The following is a description of a gene set: A conjunction of signaling from the T cell receptor, Interferon gamma (IFNG), and Interleukin-12 (IL12) induces the differentiation of T helper 1 cells (Th1) by activating the master regulator TBX21 (T-bet). Expression of TBX21 (T-bet) occurs in two phases. The first phase is dependent on IFNG acting via STAT1 and the T cell receptor acting via calcium, calcineurin, and NFATC1 (inferred from mouse homologs in Zhong et al. 2025). During the first phase, TBX21 activates expression of IL21RB2, a subunit of the receptor for IL12 (inferred from mouse homologs in Mullen et al. 2001, Afkarian et al. 2002, Schulz et al. 2009, Zhu et al. 2012). The second phase is dependent on IL12 acting via IL21RB2 and STAT4 (Inferred from mouse cells in Schulz et al. 2009, Wei et al. 2010, Zhu et al. 2012, Fang et al. 2022).<br>TBX21 with RUNX3 then enhances expression of IFNG (inferred from mouse homologs in Szabo et al. 2000, Mullen et al. 2001, Hatton et al. 2006, Djuretic et al. 2007, Jenner et al. 2009, Zhu et al. 2012), thereby creating a positive feedback loop that maintains TBX21 expression. TBX21 also binds the transcription factor RUNX1 and prevents RUNX1 from activating expression of RORC, an activator of Th17 differentiation (inferred from mouse homologs in Lazarevic et al. 2011). TBX21 also represses expression of IL4, an activator of Th2 differentiation. Thus, TBX21 restricts naive CD4+ T cells to the Th1 fate.<br>TBX21 then directly activates expression of Th1 regulators and cell markers, including C-X-C chemokine receptor type 3 (CXCR3) (inferred from mouse homologs in Szabo et al. 2000, Lord et al. 2005, Zhu et al. 2012, Gökmen et al. 2013), Tumor necrosis factor (TNF, TNFA), C-C motif chemokine 3 (CCL3). TBX21 also upregulates expression of Protein‑tyrosine sulfotransferase 2 (TPST2) (inferred from mouse homologs in Lord et al. 2005), which is linked to the ability of Th1 cells to migrate and access inflamed skin. Reactome Pathway: Differentiation of naive CD4+ T cells to T helper 1 cells (Th1 cells) studied in species Homo sapiens part of: Differentiation of T cells, and this is the list of marker genes: IFNG, IL12RB2, NFATC1, TPST2, TNF, TBX21, STAT4, RUNX1, IL4, STAT1, CCL3, RUNX3, CXCR3